The following is a description of a gene set: studied in species Homo sapiens Human Gene Set: MIR302D_5P Genes predicted to be targets of miRBase v22 microRNA hsa-miR-302d-5p in miRDB v6.0 with MirTarget v4 prediction scores > 80 (high confidence targets). from publication Chen Y, Wang X (PMID 31504780), and this is the list of marker genes: CLDN12, PWWP2A, MTMR6, CHST11, MOB3B, CCDC62, LCLAT1, ARFIP1, SEMA3D, MAFG (MAF bZIP transcription factor G), SEC23A, PDP1, PLXDC1, TMEFF1, SLU7, AEBP2, TLE4, HERPUD2, BBS5, CDCA7L, UBL3, ZNF597, DYM, NLK, SRGAP1, AFAP1L2, PHF3, BMP2K, ANK2, ALCAM, CNTN5, ZNF800, FER, TLL1 (tolloid like 1), GSDMC, FAT2, TMEM218, PPM1A, BROX, MAGEE2, TNS1, AASDH, EPHA4, DNAL1, AGFG1, ATXN7, NFRKB, INSIG2, SNX30, FAM168B, KLHDC1, ZNF91, RAB14, CISD2, LRR1, FNDC3A, ZMAT3, MINDY3 (MINDY lysine 48 deubiquitinase 3), FZD3, KCNV1, UPF3A, CD2AP, EMCN, MAP3K7, PRKG2, SPRTN, FGFR1OP2, MGAT4A, TOB1, LAMP2, PDE10A, MARF1, SLF2, FUNDC1, DOCK3, DCAF4, CCP110, SRSF2, AAK1, CBX5, NCKAP1, PRRX1, EGLN1, LIN7C, RMND5A, FBXW11 (NCBI Gene Id 23291), PNISR, SLC25A31, ADAMTSL1, SLC30A4, IGDCC3, BBX, JMJD1C, SLC1A3, SMAD3, KLHL28, XPNPEP3, OMD, GABRG1, AP1G1, GAD1, SRD5A3, MAGI3, PDGFRA, ATG4C, A1CF, PPHLN1, IPCEF1, SPPL2A, IRS1, PGM3, RNF2 (ring finger protein 2), GPHN, TTC33, BORCS7, TRIP11, FAM110C, CDK6, LYN, USPL1, SAMM50, ADAMTS5, ZNF485, PABIR3, RGL1, FMR1, CRKL, HECTD2, EML6, UBE2K, ATP2C1, PDS5A, ZNF254, ROBO2, DACH2, NR3C1, TLL2, FAM135A, RIMOC1, CEMIP2, ZMYND11, POMP, CTNND2, MON2, B3GNT5, MEX3B, KANSL2, KIF18A, GALNT13, GTF2A1, ZNF670, PGR, RAP2B, DAZAP1, RAPGEF5, DGKH, EPC2, SMAD2 (NCBI Gene Id 654050), TPM1, ATRNL1, GASK1B, CAVIN2, EXPH5, DCAF4L1, DTX3L, NF1, MITF, LRRC28, PSMC6, MSANTD3-TMEFF1, FAM174A, NCL, EHMT1, WNT3, SLC10A2, EFCAB14, SMIM13, SERINC5, CHAMP1, ZNF17, ATRX, PLAGL1, GGCX, SEMA5B, SOX6, SMARCAD1, DMXL1, CNOT6L, CDKN1B, STEAP4, CMPK1, GABRA4, ELK4, PSD3, COQ2, ANKRD30B, PLAGL2, F11R